Given this list of marker genes CFAP47, SBNO2, SEPHS2, PCDH17, XYLB, BRI3BP, SLC14A1, CRLF2, SMAP1, NFATC2, EIF1AD, SCN3B, ZNF189, FAP (fibroblast activation protein alpha), CLIP3, MKS1, RORC, IGLL5, GTF2A1, AK3, LRRTM1, SLC25A53, TBC1D19, SLC4A7, ZFP36L1, NIP7, TNFRSF11B, SYN1, AIF1L, EPG5, PLS1, ARL8B, ZMAT4, GAL3ST1, DPH6, FBXL20, ARL4C, DLX3, YY1AP1, PRAP1, PI4KB, TRAM2, GRIK5, GMPPA (GDP-mannose pyrophosphorylase A), CAMK1D, C5orf22, PLEKHH2, LTN1, TFAP4, TMEM87A, CFAP210, TENT2, SLC17A8, DND1, SLC22A6, DVL3, FCHSD1, MAML2, FAM216B, HNRNPAB, UQCRB, here is a description of the gene set: Genes predicted to be targets of miRBase v22 microRNA hsa-miR-193b-5p in miRDB v6.0 with MirTarget v4 prediction scores > 80 (high confidence targets). Human Gene Set: MIR193B_5P from publication Chen Y, Wang X (PMID 31504780) species: Homo sapiens